Given this list of marker genes Plcb1, Hotairm1, Psmb10, Ptpn22, Itfg2, Exosc3, Bcl11b, Xrcc6, Mef2c, Pparg, Clcf1, Cdk6, Paxip1, Cebpg, Lrrk2, Tac1, P2rx7 (purinergic receptor P2X, ligand-gated ion channel, 7), Pdia3, Lepr, Il11ra1, Ncstn, Men1, Xirp1, Fgf10, Cbfb, Gp5, Lrp1, Adra2b, Pbx1, Hamp, Blnk, Rhbdd3, Tespa1, Timd6, Cxcl10, Lck, Grn (NCBI Gene Id 14824), Fbxo7, Gimap1, Ifna15, Phb1, Itch, Crip3, Lipa, Cx3cl1, Znhit1, Ccdc88b, Btn2a2, Cd48, Npr2 (NCBI Gene Id 230103), Lcn10, Dnase1l3, Nckap1l, Itgav, Cd59b, Prnp, Atp11c, Fzd5, Cd44, Bag6, Lilrb4a, Fas, Nfam1, Ifna1, Fbxo38, Pou2af1, Batf2, Cbl, Gli3, Ifne, Plxna1, Il33, Clec4a3, Pibf1, Prkdc, Nfkb2, Fut7, Ptpn11, Lyn, Hes1, Nfkbid, Stat3, Smarca2, Nr1h3, Tnfrsf4, Tnfrsf9, Rasgrp1, Rbpj, Pdpn, Cracr2a, Cd5, Il1rl1, Sash3, Plcz1, Btk, Slc15a4, Ccr7, Entpd7, Rc3h2, Lrfn5, Tbx21, Pja2, Ifnb1, Slc9a6, Gpnmb, Rnf8, Sh3kbp1, Pde5a, Calhm2, Il2rg, Gnas, Fgg, Socs6, Grp, Cftr, Cd4, Edn2, Trp53bp1, Rnf41, Lcp1, Spta1, Prmt5, Ccl19-ps1, Irf4, Cebpb, Phb2, Pfdn1, Gp1bb, Tac4, Zp2, Rps6, Bcl3, Ccl21d, Lypd11, Hspa12a, Glmn, Bloc1s3, Ambra1, Ptgdr, Coro1a, Slc25a5 (NCBI Gene Id 11740), Brd4, Elf4, Snca, Abcc1, Ifngr1, Tmem98, Pla2g2a, Cd200, Tnfsf11, Irf1, C5ar1, Ighe, H2-DMb2, Tshr, Sart1, Rc3h1, Lypd10, Aif1, Ccl19, Mrgprx2, Cd37, Ap1g1, Dppa1, Impdh1, Slc39a10, Ptger4 (NCBI Gene Id 19219), Apoe, Psg21, Tsc1, Prf1, Ifna9, Kcnj8, Aire, Pms2, Ccl2, Shh, Pik3r6, Pikfyve, Socs1, Efnb2, Fyb1, Ifna16, Wnt10b, Zp3 (NCBI Gene Id 22788), Enpp3, Smo, Npy, Ascl2, Rabl3, Klrk1, Pdgfa, Ahr, Prkcz, Actl6b, Mir18, Bloc1s6, Cd274, H2-Eb2, Ppp2r3c, Ifnar2, Nmi, Cd40, Shld3, H2-DMa, Twsg1 (NCBI Gene Id 71539), Prkcb, Smad4, Tspan32, Vsir, Slfn1, Zfp609, Bcl6, Acvrl1, Ddost, Smarcd3 (SWI/SNF related, matrix associated, actin dependent regulator of chromatin, subfamily d, member 3), Lyst, Kmt2e (NCBI Gene Id 78559), Fkbp1b, Zfp683, F2r, Patz1, Relb, Myb, Tarm1, Cd320, Tbc1d10c, Azi2, Cd300lf, Pawr, Plek, Ifngr2, Slc6a4, Myo18a, Adra2a, Hells, Psmb11, Actl6a, Tfrc, Scrib, Pdgfrb, Gper1, Dll1, Dll4, Socs5, Hfe (homeostatic iron regulator), Tpd52, Arid1a, Slamf7, Ptprj, Vpreb1b, Tubb1, Lilrb4b, Apc, Txlna, Dock11, Gm13275, Hmces, Kmt2a, Mapk8ip1, Il23a, Wwp1, Flt3l, Emilin1, Ccl5, Gapt, Tnfsf14, Pag1, Gla, Ceacam1, Ifnz, Anxa1 (NCBI Gene Id 319730), Sox15, Ccl21f, BC037156, Dnaja3, Slfn2, Pglyrp2, Sit1, Il18rap, Lbp, Lef1, Stat5b, Tcirg1, Tsc2, Itk (NCBI Gene Id 16428), Cd8a, Actb (actin, beta), Spib, Il27 (interleukin 27), Mad2l2, Crlf2, Pdpk1, Fkbp1a, Pdia2, Cela2a, Igtp, F2rl1, Igf1, Slc4a1, Fcrl1, Gata2, Ndfip1, Rab44, Smarcb1, Dgat1, Batf, Cd226, F2, Ceacam14, Scnn1b, Tacr1, Fzd6, Rgcc, Itpkb, Slc7a11, Drosha, Ywhaz, Nectin2, Cd47, Milr1, Mrgprb1, Fancd2, Polm (NCBI Gene Id 54125), Ifna13 (NCBI Gene Id 230396), Ctnnb1, Mir301, Lyl1, Chrna7, Pglyrp1, Gsk3b (NCBI Gene Id 98033), Il9, Fam76b, Sucnr1, Ildr2, Nsd2, Rbx1, Cd74, Rab27a, Lag3, Rabgef1, Selenok, Sp3, Fanca, Mpl (myeloproliferative leukemia virus oncogene), Myh9, Rag1, Pou1f1, St3gal1, Tlr6, Loxl3, Bst1, Ticam1, Adora3, Lgals1, Sos2, Tmx1, Tlr3, Egr3, Ankle1, Cd209d, Srf, Bcl10, Zc3h12d, Fgr, Adam9, Emilin2, Cd59a, Tmem106a, Tlr2, Prkcq, Myd88, Vwf, Dicer1, Ifna6, Mir19a, Prelid1, Dpp4, Sox12, C3, Smarcc1, Mif, Cxcl5, Cd244a, Itgb6, Prkg1, Muc5b, Fgfr1, Ceacam13, Cd300a, Msh6, Ifnar1, Prkar1a, Smad7, Tirap, Opa1, Hdac9, Cd69, Gna13, Ighm, Cd180, Bmper, Sh3rf1, Vtcn1, H2-Oa, Ighg1, Cd19, Mr1, Ripk3, Ifna2, Cxcr5, Il10, Cd8b1, Psg19, Irgm1, Ifna12, Gnaq, Mmp8, Smarce1, Ephb4, Kat7, Tec, Lgals3, Lat, Ephb1, Bad, Zfp35, Bax, Sanbr, Bcl11a, Fzd7, Myc, Dusp22, Pck1, Psg17, Ldlr, Zfp608, Egr1, Ifi35, Havcr1, Usp44, Hspa4, Ager, Atf2, Foxn1, Nod2, Kat2a, Dnajb9, Cd209a (CD209a antigen), Cgas, Ctsl, Bpi, Crtc3, Tnfsf8, Slc46a2, Src, Hdac5, Satb1, Hspd1, Nkx2-3, Il12rb1, Csf1r, Efnb1, Samsn1, Egfr, Ms4a1, Il12a, Lat2, Stat5a, Dusp3, Tlr9, Il12b, Tpst2, Pbrm1, Itgad, Fga, Gclc, Ifna11, Klrd1, Cxcr4, Hsph1, Psg27 (pregnancy-specific beta-1-glycoprotein 27), Fcgr4, Ikzf1, Cd80, C1qtnf1, Psen2, Spi1, Atad5 (NCBI Gene Id 319895), Akap12, P2rx1, Il27ra, Tyrobp, Adora2b, Rassf5, Kars1, Nhej1, Rab29, Ncr3-ps, Fer, Gm13276, Cdh17, Ifna5, Nr4a3, Adamts18, Vamp8, Rif1, Cd276, Kdelr1, Trex1, Fn1, Zfp335, Pdgfb, Tox, Ccr6, Anxa3, Dcaf15, Smarca4, Ms4a2, Bank1, Cdkn2a, Ccr9 (C-C motif chemokine receptor 9), Dnase1, Cd79b, H2-Ob, Itpripl1, Fcer1g, Ctsc, Zap70 (NCBI Gene Id 98322), Selp, Thy1, Cd86, Bloc1s4, Nfatc3, Kmt5c, Il1a, Cst7, Tyk2, Nfkbiz, Btnl2, Ccnd3, Dock2, Flna, Pax1, Ctps1, Washc1, Pdia4, P2ry1, Evl, Ung, Cr2, Icos, Slamf8 (NCBI Gene Id 74748), Gal, Tnfrsf1b, Il5, Plat, Prkce, Mir505, Tnfaip3, Sh2d1a, Runx2, Fzd9, Camp, Abl1, Bid, Vnn1, Clec7a, Tigit, Cx3cr1 (C-X3-C motif chemokine receptor 1), Ido1, Ly6d, Nrarp (NCBI Gene Id 67122), Foxp3, Cul4a, Git1, Il1rl2, Timd5, Yy1, Treml2, Trp53, Gm13271, Armc5, Raet1d, Alox12, Il7r, Ubash3b (ubiquitin associated and SH3 domain containing, B), Wnt4, Cd22, Arid2, Zbtb1, Otud5, Pla2g2d, Ccl3, Irf8, Themis2, Clec4g, Pla2g2f, F2rl3, Gata1, Plcg2, Plscr2, Tnfsf13b, Igbp1, Mpzl2, Il18, Gkn2, Gp6, Pdgfra, Msh2, Nppa, Stxbp2, Pglyrp4, Klf5, Mlh1, Adora2a, Snx4, Vps33b (vacuolar protein sorting 33B), Il2, Rpl22, Ppia, Casp1, Ccl19-ps4, Mfhas1, Tgfb1 (NCBI Gene Id 21803), Fcer1a, Gpr18 (NCBI Gene Id 263515), F11r, Notch2, Blm, Ceacam11, Ptafr (NCBI Gene Id 636551), Stat4, Zbtb7a, Clec12a, Onecut1, Megf10, Hoxa9, Adam10, Swap70, Psg28, Jund, Pten (phosphatase and tensin homolog), Lrrc32, P2ry12, Lax1, Thbs1 (NCBI Gene Id 21825), Hspb1, Tnfrsf13c, Ccr2, Fnip1, Clptm1, Rasal3, Cd38, Top2b, Vamp2, Igfbp2, Marchf7, Adam8, Zc3h12a, Cd40lg, Psen1, Kcnn4, Ndrg1, Cyld, Syvn1, Il15ra, App, Vav3, Pla2g10, Atg5, Tex101, Ddr2 (NCBI Gene Id 98699), Cd28, Pilrb1, Gadd45g, Slc11a1, Lgals9, Igkc, Rasa3, Il4i1, Ephb2, Cxadr, Ywhag, Card11, Fyn, Slc7a1, Mertk, Mink1, Inpp5d, Shpk, Adgrg3, Mzb1, Mdm2, Ccl19-ps6, Btnl6, Smarcd2 (NCBI Gene Id 83796), Eif2ak4, Btla, Dapl1, Clec4e, Cblb, Msn, Prg3, Aqp8, Lig4, Adrm1, Cd79a, Nr4a1 (nuclear receptor subfamily 4, group A, member 1), Nfatc1, Serpine2, Plcl2, Foxp1, Prr7, Cplx2, Cd151, Rps6ka1, Hrg, Fundc2, Lmo4, Psg23, Dock10, Ighd, Pik3cb, Stoml2, Sox13, Tnip2, H2-T23, Pirb, Pdia6, Supt6, Ifna14, Ebi3, Flt3, Vpreb1a, Camk4, Tlr4, Ccl20, Wnt1, Skint1, Klhl22, Snhg15, Ugt1a1, Lrrc8a, Itm2a, Prex1, Tmem229b, Scgb1a1, Ubd, Brd2, Ttbk1, Fadd, Hhex, Nfil3, Sphk2, Runx1, Il18r1, Tcim, Pla2g3, Cd24a, Rbx1-ps, Exo1, Il9r, Erbb2, Nedd4, Zbtb32 (NCBI Gene Id 80652), Mir92-1, Dcaf1, Zmiz1, Ccl21b, Stx11, Cd70, Irs2, Psap, Tyro3, Nedd9, Ptpn6, Treml1, Cfb, Camk2b, Cd160, Ulbp3, Enpp1, Muc19, Slamf1, Exosc6, Trim55, Jun (NCBI Gene Id 16476), Fermt3, Igbp1b, Il6st, Bmi1, Tmem131l (NCBI Gene Id 229473), Sox4, Alkbh5, Dusp10, Cntf, Tff2, Sema4a, Fgl1, Mir7116, Agt, Cfh, Zc3h8, Zeb1, Fcer2a, Rps3, Lep, Kit, Ntrk1, Vsig4, Siglecg, Mir326, Adam17, Efnb3, Ufl1 (NCBI Gene Id 67490), Ccn2, H2-Ea (NCBI Gene Id 14968), Mtor, Cd3d, Nck2, Gpr15lg, Ercc1, Ctsg, Nlrp5, Rian, Mir181b-1, Stx4a, Stk39, Hsp90aa1, Prkcd, Ifng, 6030468B19Rik, Ptk2b, Casp3, Hmga1, Lmbr1l, Hmgb1, Phf14, Cyrib (NCBI Gene Id 76270), Wdfy4, Sftpd, Rsad2, Ins2, Ifna7, Il6, Ihh, Runx3, Kat5, Tspan9, Hdac7, Cd27, Il13 (NCBI Gene Id 16163), H2-Ab1, Tlr1, Btnl1, Ezh2, Gm36723, Htr2a, Cebpa, Itgb8, Irf2bp2, Nppc, Zp1, Pla2g4a, Il21, Unc13d, Chga, Cd209c, Cd84, Pla2g5, Pear1, Mill1, Zbtb7b, Gnrh1, Tnfsf18, Il13ra2, Tcf7, Cdh26 (cadherin-like 26), Dlg5, Fgl2, C1qa, Abr, Ins1, Foxf1, Il3, Ptpn2, Parp3, Stard7, Dcstamp, Adk, Slamf9, Pkn1, B2m (NCBI Gene Id 12010), Mafb, Tnfaip8l2, Nbn, Adam24, Epsti1, H2-M3, Adgrf5, Ptgds, Fcgr3, Tcf4, Batf3, Scart2, Ulbp1, Psg16, Slc18a2, Il2ra, Myocd, Gab2, Prdm1, Tnf, Prlr, Cd3e, Aicda, Ifnk, Mir181b-2, Ppp3cb, Entpd2, Mmp14, Rora, Wnk4, Timd2, Traf3ip2, Mmrn1, Ephb6, Sla2, Cd6, Hprt1, Cmtm7, Fcgr2b, Gp1ba, Kmt5b, Tbk1, Zfp36l1, Rorc, Arg2, Naglu, Peli1, Dtx1, Csf2, Gata3, Gimap3, Cd2, Rhoa, Il7, Fes, Hmgb3, Foxj1, Atm, Clec2i, Smarcc2, Akirin2, Cd209e, Tgfbr1, Pagr1a, Ptcra, Ifnab, Dhps, Rac2, Clnk, Mir19b-1, Apbb1ip, Fam114a1, Cacnb4, Ctla2a, Gjd4, Clec4a4, Bak1, Mir873a, Rag2, Il1b, Stxbp3, Tnfrsf13b, Tcf3, Nfatc2, Igf2, Il36b, Sh2d1b1, Xcl1, Tusc2, Vcam1 (NCBI Gene Id 22329), Mfng, Nr5a2, Chrna4, Ccl19-ps3, Ccl19-ps5, Pglyrp3, Itgal (NCBI Gene Id 16408), Zeb2, Ccl21a, Tnfrsf21, Rhoh, Cyp26b1, Gsn, Il4, Pdcd1, Emp2, Gm13283, Cd300lb, H2-DMb1, Il17a, Cxcr2, Cd83, Fzd8, Vav1, Hectd1, Il16, Sox11, Snap23, Trem2, Selplg, Bcl2a1d, Jaml, Tnfrsf14, Adra2c, Phf10, Mdk, Nkap, Ceacam3, Ap3b1, Smad3, Pip5k1c, Clu, Pld2, Sema6d, C1galt1c1, Clec4d, Syk, Clec4a2, Klre1, Ptpre, Dcaf12, Pknox1, Abl2, Mfsd2b, Astl, Pcyt1a, Skap2, Lmo1, Cxcl12, Axl, Il6ra, Pram1, Capn3, Cav1, Chrnb2, Cd1d1, Slc39a6, Foxo3, Epo, Pik3cd, Nkg7, Gps2, Cd9, Bcl2, Pycard, Prdx1, Itgb2, Id2, Gpr89, Itgb2l, Mad1l1, Ltbr, Kctd9, Ubash3a, Il15, Gas6, Ap3d1, Comp, Jag2, Klhl25, Cd81, Laptm5, Sphk1 (NCBI Gene Id 66122), Ccl21e, Cd55b, Pi4k2a, Cnr2 (NCBI Gene Id 12802), Tnfsf9, Rap2b, Sdc4, Csk (NCBI Gene Id 12988), Lgals8, Carmil2, Gm13272, Trpv1, Cd1d2, Shld1, Rnf168, Stap1, Gpr137b, Psg26, Pf4, Ceacam12, Themis, Shld2, Nr1d1, Xbp1, Eomes, Crhr1, Ctla4, Lcp2, Pura, Wnt3a, Myo1f, Ulk3, Ptprc, Hps1, Shb, Gon4l, Slc4a2, Ncor1, Acta2, Itpr3, Sfrp1, Il17ra, Scn11a, Jak2, Pcid2, Fosl2, Gclm, Sh2b3, Traj18 (NCBI Gene Id 100124371), Cd2ap (CD2-associated protein), Braf, Pdcd1lg2, Chd7, H2-Eb1, Slc39a7, Mir150, Tnfsf13, Flot2, Krt2, Snhg20, Txk, Malt1, Ncaph2, Pnp, Pik3r1, Dclre1c, Igkj5, Ripor2, Prkaa1, Ep300, Dysf, Duxbl1, Cdkn1a, Stk11, Brd7, Psg25, Xrcc4, Ripk2, Grb2, Bcr, Mettl3, Lst1, Sirpa, Mir20a, Traf6, Wnt5a, Itgam, Hmox1, Traf2, Itgax, Prdx2, Svep1 (NCBI Gene Id 80647), Zfp36l2, Lilra5, Syt11, Il4ra, Crtam, Wbp2nl, Hlx, Gbf1, Tgfbr2, Hyal2, Gja1, Ly9, Ddrgk1, Mir17, Slc7a2, Cd55, Arg1, Gpr183, Was, H2-Aa, Havcr2, Kcnk18, Tslp, Mcub, Plscr1, Ppp3ca, Wnt7a, Sh2d1b2, Hs1bp3, Ada, Ceacam5, Nlrc3, Spn, Gpam, Impdh2, Prkca, Il20rb, Gm11690, D6Wsu163e, Icosl, Sbno2, Gimap5, Nck1, Rara, Clec4f, Tnfsf4, Pou2f2, Ceacam15, Jmjd6, Lfng (NCBI Gene Id 16848), Ceacam23, Nlrp3, Sos1, Gba1, Lamp1, Icam1, Stat6, Bmp4, Ifna4, Cd177, Stxbp1, Cast, Jak3 (NCBI Gene Id 16453), Plpp6, Zbtb46, Gm13277, Cnr1, Tafa3, Dlg1, Gp9, Cd46 (CD46 antigen, complement regulatory protein), Ikzf3, Cd3g, Slamf6, Itgb3, Sh2d2a, Aplf, Nampt, Cygb, Atp7a, Entpd1, Klrb1c, Fcho1, Kitl, Smarcd1, Dock8, Kpna1, Fgb, Hsh2d, here is a description of the gene set: Mouse Gene Set: GOBP_CELL_ACTIVATION A multicellular organismal process by which exposure to an activating factor such as a cellular or soluble ligand results in a change in the morphology or behavior of a cell. species: Mus musculus